The following is a description of a gene set: species: Homo sapiens Human Gene Set: GOBP_LNCRNA_TRANSCRIPTION The transcription of lncRNAs, non-coding RNAs over 200 nucleotides in length, from a DNA template., and this is the list of marker genes: WDR82, TOPAZ1, CELF3, ZC3H4, IQCH, NFATC2